The following is a description of a gene set: Human Gene Set: GSE23505_UNTREATED_VS_4DAY_IL6_IL1_IL23_TREATED_CD4_TCELL_DN Genes down-regulated in CD4 T cells: untreated versus IL1B, IL6 and IL-23. CD4+ T cells that selectively produce interleukin (IL)-17, are critical for host defense and autoimmunity1-4. Crucial for T helper17 (Th17) cells in vivo5,6, IL-23 has been thought to be incapable of driving initial differentiation. Rather, IL-6 and transforming growth factor (TGF)-β1 have been argued to be the factors responsible for initiating specification7-10. Herein, we show that Th17 differentiation occurs in the absence of TGF-β signaling. Neither IL-6 nor IL-23 alone efficiently generated Th17 cells; however, these cytokines in combination with IL-1β effectively induced IL-17 production in naïve precursors, independently of TGF-β. Epigenetic modification of the Il17a/Il17f and Rorc promoters proceeded without TGF-β1, allowing the generation of cells that co-expressed Rorγt and T-bet. T-bet+Rorγt+ Th17 cells are generated in vivo during experimental allergic encephalomyelitis (EAE), and adoptively transferred Th17 cells generated with IL-23 in the absence of TGF-β1 were more pathogenic in this experimental disease. These data suggest a new model for Th17 differentiation. Consistent with genetic data linking the IL23R with autoimmunity, our findings re-emphasize the role of IL-23 and therefore have important implications for the development of new therapies. from publication Ghoreschi K, Laurence A, Yang XP, Tato CM, McGeachy MJ, Konkel JE, Ramos HL, Wei L, Davidson TS, Bouladoux N, Grainger JR, Chen Q, Kanno Y, Watford WT, Sun HW, Eberl G, Shevach EM, Belkaid Y, Cua DJ, Chen W, O'Shea JJ (PMID 20962846) studied in species Homo sapiens, and this is the list of marker genes: TK2, C12orf57, HLA-DOB, CORO2A, PREX1, CD40, HR, GATA6 (NCBI Gene Id 2627), AKAP13, C8orf58, PPP3CC, KLHL14, RAP1GDS1, VTN, NRTN, SPATA13, MREG, PGM1, SLC6A7, ARPC5L, TRIM14, CALHM6, ASCC1, ERICH2, SLC26A11, GIMAP1, S1PR3, CWC15, TREML2, CCRL2, KCNQ3, AGMO, INKA1, TRIM7 (NCBI Gene Id 81786), ZMAT3, TNFAIP8L2, ID1, TGFB3, VPS37B, MBNL1, CD74, CARD6, FCMR, HLA-DOA, BCAR3, PHF1, INVS, ABLIM1, SMPD3, KMO, SLC6A13, LTB, NKAIN1, IAH1, HPS3, FAS, DELE1, S1PR1, CTSH, SLC25A19, MIA, GPR18, SORBS1, MAN1A1, LPAR6, SLC46A1, CD22, MAPK14, SUSD3, CR2, IFFO1, PLEKHM1, ORC5, FERMT3, GSN, BCL2, PTPN6, DNAH12, RINL, DEPDC7, RTN4R, RGS2, HLA-DQA1, P2RY10, GCNT1, BCL6, RAPGEF3, NOP53, RALGPS2, ALDH1B1, ATP2A3, STOX1, WDR41, SEC22C, HLA-DMB, HLA-DRB1, TNFRSF13B, SESN3, PDIA5, CD2, PCDHB4, WHAMM (NCBI Gene Id 123720), CNST, DAP3, RMND1, KLHDC1, SLC46A3, CD93, PRRT3, CD48, SESN1, NAXE, THTPA, LRRK2, GAP43, FCER2, B3GNT7, JAK1, SEPTIN9, SIRT7, BASP1, SYT11, CD28, RGL1 (ral guanine nucleotide dissociation stimulator like 1), SERPINI1, THNSL1, CD38, INSYN1, ENDOU, GRB2, TLE5, C19orf12, CNR2, CYTIP (NCBI Gene Id 9595), CCNG2, TRIM59, PLPP1, MAP3K10, ETS2, MPP1, ARAP2, HLA-E, FAM20C (FAM20C golgi associated secretory pathway kinase), RAD51B, GYS1, TEC, HOPX, CABLES1, GALNS, TNNI2, GSTO2, LMO2, CRIP1, SEMA4B, LEPROT (leptin receptor overlapping transcript), ACP6, NEDD4L, PTPRE, EBI3 (Epstein-Barr virus induced 3), MKRN1, HORMAD1, ICOSLG, PPDPF, CCR5, OAZ2, IFI27, KLRD1, CYP4F3, GPSM3, TRAP1, CCR10, CEP350, ATOSB, CD36, ZNF449, NIPAL3, HLA-DMA, KLHL6, LMO7, GALNT12, SDHAF4, ETHE1, LY6E, BEND5, SLTM, BSPRY, CCDC88C, BANK1, COMMD3, ARHGAP45 (NCBI Gene Id 23526), CASP6 (caspase 6), ADGRE1, SPINDOC, HAAO, CYTH1, KIF21B, UNC13D, ASAP1, NBR1